Given this list of marker genes POLE2, RIOK3, EIF2AK2, CCNE2, POLD3, CD3E, DNPH1, AURKA, ZNF330, ZWINT, BEST1 (NCBI Gene Id 7439, bestrophin 1), NF1, PFDN1, NCOA6, KNTC1, TLK1, AIF1, UBE2C, ILF3, RAD21, ZMYND11, IGHMBP2, KATNA1, LCK, PLK4, NME2 (NME/NM23 nucleoside diphosphate kinase 2), PPP2R1A, PLK1, EMP3, TUBE1, GFI1, HDAC4, BST2, MCM7, GRN, SIPA1, RAD51D, LST1, PA2G4 (NCBI Gene Id 5036), CTBP1, PMS1, IL2RG, HMGA1, USP16, RBM14, IFI16, CDK2AP1, IFRD2, CXCL8, IFITM1, WT1, NFIC, MYC, NBN, LIG3, CDC7, CUL1, MAP3K20, DTYMK, REPIN1, TNFRSF8, CCNB2 (NCBI Gene Id 9133), SUV39H1, S100A11, ATF5, MCM5, TFDP2, BCAT1, MCM3, NUBP1, CETN3 (NCBI Gene Id 1070), here is a description of the gene set: Histone deacetylase inhibitors (HDACis) inhibit tumor cell growth and survival, possibly through their ability to regulate the expression of specific proliferative and/or apoptotic genes. However, the HDACi-regulated genes necessary and/or sufficient for their biological effects remain undefined. We demonstrate that the HDACis suberoylanilide hydroxamic acid (SAHA) and depsipeptide regulate a highly overlapping gene set with at least 22% of genes showing altered expression over a 16-h culture period. SAHA and depsipeptide coordinately regulated the expression of several genes within distinct apoptosis and cell cycle pathways. Multiple genes within the Myc, type beta TGF, cyclin/cyclin-dependent kinase, TNF, Bcl-2, and caspase pathways were regulated in a manner that favored induction of apoptosis and decreased cellular proliferation. APAF-1, a gene central to the intrinsic apoptotic pathway, was induced by SAHA and depsipeptide and shown to be important, but not essential, for HDACi-induced cell death. Overexpression of p16(INK4A) and arrest of cells in G(1) can suppress HDACi-mediated apoptosis. Although p16(INK4A) did not affect the genome-wide transcription changes mediated by SAHA, a small number of apoptotic genes, including BCLXL and B-MYB, were differentially regulated in a manner consistent with attenuated HDACi-mediated apoptosis in arrested cells. We demonstrate that different HDACi alter transcription of a large and common set of genes that control diverse molecular pathways important for cell survival and proliferation. The ability of HDACi to target multiple apoptotic and cell proliferation pathways may provide a competitive advantage over other chemotherapeutic agents because suppression/loss of a single pathway may not confer resistance to these agents. from publication Peart MJ, Smyth GK, van Laar RK, Bowtell DD, Richon VM, Marks PA, Holloway AJ, Johnstone RW (PMID 15738394) Cell proliferation genes down-regulated by histone deacetylase (HDAC) inhibitors SAHA and depsipeptide. studied in species Homo sapiens Human Gene Set: PEART_HDAC_PROLIFERATION_CLUSTER_DN